Given this list of marker genes Oas1e, Tent4b, Papolg, Oas1f, Nmnat1, Tent5d, Oas1g, Oas1h, Nmnat2, Papola, Mtpap, Papss2, Tut1, Oasl2, Tent4a, Mocs3, Tent5b, Oas1d, Tent5a, Oas3, Papolb, Oas1b, Oasl1, Selenoo, Gphn, Kars1, Oas1a, Gars1, Oas2, Coasy, Tent5c, Oas1c, Fhit, Flad1, Papss1, Ficd, Tent2, Nmnat3, here is a description of the gene set: Mouse Gene Set: GOMF_ADENYLYLTRANSFERASE_ACTIVITY studied in species Mus musculus Catalysis of the transfer of an adenylyl group to an acceptor.